Given this list of marker genes Zfp418, Usp38, Panx1, Rbfox2 (NCBI Gene Id 93686), Tgm6, Nudt7, Tyro3 (TYRO3 protein tyrosine kinase 3), Fam135a, Pate5, Ret, Tshr, Prickle2, Sec24c, Camk2a, D5Ertd579e, Cirbp, Kif21a, Cebpg, Sp1, Ahcy, Zfp655, Tmem127, Zmynd11, Gm11541, Zfp24, Tbl1xr1, Mbd1, Stbd1, Atf3, Pramel47, Mapk10, Zfp711, Nphs2, Myo1e, Ptprm, Mnt, Rbms2, Cfap418, St3gal1, Arhgap24, Uck1, Sdc4, Gna13, Fam53c, Ppp1r26, Apc, Cebpe (CCAAT/enhancer binding protein epsilon), Eif5a2, Ptbp2, Clmn, Klf2, Bckdhb, Lmx1a, Rab1a, Atf7, U2surp, Sox5, 4930402K13Rik, Cxxc4, Gata6, Hspa5, Wee2, Sema4a, Csnk1d, Bhlhe22, Cacna1c, Gm5916 (NCBI Gene Id 639015), Dner, Kif1a, Slc25a42, Pdik1l, Bsnd, Tcf4, Hnrnpk (heterogeneous nuclear ribonucleoprotein K), Kpna1, Nynrin, Rbpj, Lamp2, Aco2 (aconitase 2, mitochondrial), Med24, Melk, Yju2b, Dnajc11, Rbm39, Mtfp1, Fam228b, Tbc1d2b, Eif4g1, Dach1, Zfand6, Cyb5d2, Tbx5 (T-box 5), Avil, Hip1r, Sv2a, Tbc1d4, Actb, Arcn1 (NCBI Gene Id 213827), Cdkl4, Slc4a8, Entrep2, Bcl9l, Ky, Zc3h12a, here is a description of the gene set: studied in species Mus musculus Genes predicted to be targets of miRBase v22 microRNA mmu_miR_3058_5p in miRDB v6.0 with MirTarget v4 prediction scores > 80 (high confidence targets). Mouse Gene Set: MIR_3058_5P from publication Chen Y, Wang X (PMID 31504780)